The following is a description of a gene set: Mouse Gene Set: GOBP_POSITIVE_REGULATION_OF_PATTERN_RECOGNITION_RECEPTOR_SIGNALING_PATHWAY species: Mus musculus Any process that decreases the rate, frequency or extent of a pattern recognition receptor signaling pathway., and this is the list of marker genes: Slc15a3, Pik3ap1, Ninj1, Peli3, D1Pas1, Tasl, Cd14, Wdfy1, Gbp2, Rsad2, Ifi35, Ddx3x, Pja2, Lbp, Pum1, Usp50, Nr1h3, Slc19a1, Zdhhc1, Pum2, Lats1, Tlr1, Stmp1, Cyba, Cd36, Dhx33, Plcg2, Tirap, Nagk, Casp4, Mavs, F2rl1, Gbp5, Ticam2 (TIR domain containing adaptor molecule 2), Tlr4, Ptpn22, Usp15, Flot1, Usp17le, Znrf1, Dhx58, Zc3hav1, Ltf, Cd300ld3, Mapk8, Trim15, Atat1, Hspa1b, Zcchc3, Tlr9, Gdi1, Ddx60, Lats2, Btk, Tab1, Tlr6, Prkd1, P2rx7, Ccdc134 (coiled-coil domain containing 134), Zdhhc9, Map3k7, Nek7, Ankrd17, Slc15a4, Hmgb1, Lrch4, Zdhhc5, Peli1, Brcc3, Cav1, Trim3, Ppp2ca, Zdhhc3, Gm12250, Myd88 (myeloid differentiation primary response gene 88), Treml4, Mark4, Rtn4, Oasl1, Slc46a2, Brcc3dc, Mfhas1